Given this list of marker genes GRIN2B, MSX1, PODXL, ANGPT2, ATOH1, OCA2, FZD4, RAMP1, CXCL2, GTPBP2, UTP20, NFIB, CGA, AKR1C2, SNORA7A, UQCC5, ARIH2, ARMCX2, RBM15, CRYAB, CDKN2AIPNL, CIB1, RRP9, MAP7, TDO2, PSCA, STC1, RUVBL2, MRPL9, DARS1, GUF1, DSP, NUSAP1, TOP1, KRT7, SLC1A2, ZNF799, GATA2, TENM2, HOXA10, VWA7, AP1M1, KCNA7, HSPA1A, CNOT2, HBG2, CRYAA, MMP24, BRD4, FSTL1, NXPH2, SCN9A, CLCN2, NEK1, GLI3, MAPKAPK2, NFATC1, SLC10A3, CYP2S1, NKIRAS2, TBR1, SPOCK1, PFKFB1 (NCBI Gene Id 5207), PSMG1, GPR162, PHKB, PROM1, NPNT, PSAP, PHKG1, SYT4, PRKD2, CENPL, HEBP1, ACTN3, HSPBP1, LY6H, MFAP4, CBX6, NOS2, SLC6A15, HEMGN, STAB1, KCNS1, PDRG1, STAM, FLCN, AMBRA1, ZNF322, SERPINA10, CYP2B6, SRA1, GMIP, CEBPA, SATB1, PPP4R2, PRPH2, SFMBT2, CCDC28B, CDH11, SNIP1, CAMK2B, KLF10, OC90, CRYBA1, LRPPRC, USP39, BMP8A, FER, NSG2 (neuronal vesicle trafficking associated 2), GFM1, ZBED3, KRT8, SEMA3C, MAPK13, COPS3, NSMF, IFRD2, NR1I2, GZMK, RTTN (NCBI Gene Id 284278), DNASE1L3, TNIP1 (TNFAIP3 interacting protein 1), RGS9, TPBG, PAK2, CUL1, PDC, CLCN7, OST4, SRMS, HOXD3, TEAD1, MMP10, PHC1, REM1, CMTM4 (NCBI Gene Id 146223), IYD, GHRH (growth hormone releasing hormone), AARS1, NET1, POLDIP2, CLGN, PLEKHB2, TFCP2L1 (NCBI Gene Id 29842), CKAP4, RAB25, FAM20C, CORT, SOX3, FANCM, FAM117A, CPS1, ARHGDIB, MC5R, TLX3, CCNB1IP1, TLL1 (tolloid like 1), GABRG3, ABCC9, NFU1, CSTPP1, SERPINA6, LINC00612, ANKRD49, RBKS, BMP7, RHOB, CHKA, MAP1LC3A, ARHGAP45, MAP6, TNFRSF18, DVL1, COMMD1, BCL6, FIS1, BCL2A1, EFHD1, PRKCE, GPN3, DUSP6, DHX30, ZBTB25, ZNHIT2, FBN1, ERGIC2, PER3 (NCBI Gene Id 8863), TNFAIP2 (TNF alpha induced protein 2), CTSW, CANT1, EMCN, TLCD4, FBXW4, ZNF740, TRIM13, STK10, VEGFD, GABRR1, TEK, here is a description of the gene set: Genes down-regulated in CD4 T helper cells (1h): Th0 versus TGFB1 and IL6. species: Homo sapiens Human Gene Set: GSE43955_TH0_VS_TGFB_IL6_TH17_ACT_CD4_TCELL_1H_DN from publication Yosef N, Shalek AK, Gaublomme JT, Jin H, Lee Y, Awasthi A, Wu C, Karwacz K, Xiao S, Jorgolli M, Gennert D, Satija R, Shakya A, Lu DY, Trombetta JJ, Pillai MR, Ratcliffe PJ, Coleman ML, Bix M, Tantin D, Park H, Kuchroo VK, Regev A (PMID 23467089) Despite their enormous importance, the molecular circuits that control the differentiation of Th17 cells remain largely unknown. Recent studies have reconstructed regulatory networks in mammalian cells, but have focused on short-term responses and relied on perturbation approaches that cannot be applied to primary T cells. Here, we develop a systematic strategy – combining transcriptional profiling at high temporal resolution, novel computational algorithms, and innovative nanowire-based tools for performing gene perturbations in primary T cells – to derive and experimentally validate a temporal model of the dynamic regulatory network that controls Th17 differentiation. The network is arranged into two self-reinforcing and mutually antagonistic modules that either suppress or promote Th17 differentiation. The two modules contain 12 novel regulators with no previous implication in Th17 differentiation, which may be essential to maintain the appropriate balance of Th17 and other CD4+ T cell subsets. Overall, our study identifies and validates 39 regulatory factors that are embedded within a comprehensive temporal network and identifies novel drug targets and organizational principles for the differentiation of Th17 cells.